The following is a description of a gene set: Genes predicted to be targets of miRBase v22 microRNA hsa-miR-6132 in miRDB v6.0 with MirTarget v4 prediction scores > 80 (high confidence targets). studied in species Homo sapiens from publication Chen Y, Wang X (PMID 31504780) Human Gene Set: MIR6132, and this is the list of marker genes: PABIR3, EFNB1, MLXIP, RUFY1, C6orf89, KSR2, NPLOC4, MAFG, RAPGEFL1, ADAMTS10, BAHD1, KIF21B, BTN2A2, ATG9A, DUSP26, CAMK2G, ESRRA, SH3PXD2B, ATP6V0A1 (ATPase H+ transporting V0 subunit a1), IQSEC2, N4BP3 (NEDD4 binding protein 3), NUDT5, RING1, TSPAN7 (tetraspanin 7), SRP68, PEX16, CARMIL1, CACNB3, CGREF1, ZMAT3, LSM12, XPO7, SALL1, PLCXD3, TPRA1, CANX, ERCC6L, SLC2A13, SNPH, SFTPB, PTAR1, CAVIN1, ADAM11, JDP2, ADGRE2, ZKSCAN2, STAG1, LARGE1, TMEM25, MSL1, PLAG1, JADE2, RAB23, MPZ, UBE2V1, LRP3, TEX19, EIF2AK1, MVB12A, LAMTOR3, RORA, STEAP3, SYK, LDLRAP1, STOML1, HRH3, MYOCD, VANGL2, ADCYAP1R1, PLEKHH3 (NCBI Gene Id 79990), GRM7, SHC3, RIC3, SSH3, MTCP1, TNPO1, MBD3, ARNT2, CNNM4, ZDHHC22, TRMT61A, AMZ1, UBE2H, ZCCHC24, CAMKV, RASGEF1A, RAB4B, LHPP (phospholysine phosphohistidine inorganic pyrophosphate phosphatase), MTCL2, MARCHF3, RAB1B, UBA7, VPS39, MGAT5 (NCBI Gene Id 4249), EMILIN3, PIPOX, CASP10, FEM1C, MAPK1, RNF216, PCYT2, MEF2D, TTYH2, CDC42, PHF19, ATP5F1D, NUFIP2 (nuclear FMR1 interacting protein 2), TTYH3, CNTNAP2, PUM1, PLXNA2, NFIX, FGF1, KRTAP10-7, DOCK9 (dedicator of cytokinesis 9), NR6A1, RC3H1, E2F7, NFAM1, ACAP3, ZNF704, ARHGEF9, FOXN4, CEMIP, RLN3, PRRT2 (proline rich transmembrane protein 2), TGIF2, RIMS3, PAQR4, CAPNS1, BTN2A1, CALML5